Given this list of marker genes HOXA7, HCAR3, SSX9P, GLB1L3, LOX, GPR27, SCN3A, BAZ1A, DLGAP4, KRTAP15-1, RTL3, CEP15, KCTD5, IGF1, SLITRK4, NDRG2, GPM6A (NCBI Gene Id 2823), TPT1P8 (TPT1 pseudogene 8), FIGN, EYA1, ADNP2, HNF1B, P2RY10, MBD5, PDE4D, PLAG1, DLG2, SSX7, HOXD4, LDB2, MBNL1, SRSF1, PPP1R36, CHD9, PDZRN4, VPS37A, UCMA, MNT, SULF2, ID4, TRERF1, DHRS4, LIN54 (lin-54 DREAM MuvB core complex component), HOXB8, GNAO1, GPC4 (NCBI Gene Id 2239), DPYSL3, CDC42EP3, KLHL13, LMO3, DCANP1, ANK3, PHOX2B, MID2, NFIA, MPPED2, GPRIN3, PITX2 (NCBI Gene Id 5308), MECOM, MCTS1, DLX1, DUSP10, CCDC116, CIAO1, KLF15, CELF2, OMG, H2AC1, MAF, SRSF6, BRINP3, TLE3, DCUN1D3, SEMA6A (semaphorin 6A), ELP4, FEZF2, HNRNPLL, NDST4, MAP4K5, FGF19, SATB1, GRM7, KLHL11, TSNAX, INPP4A, EP300 (E1A binding protein p300), BCL2, ZRANB1, ERBB4, CETN1, YRDC, C1orf122, IMMP1L, NCOA3, TENM3-AS1, NFIB, H3-3B, OPN5, TMEM178A (transmembrane protein 178A), SERTAD4, PLXNA2, SLC26A7, HIPK1 (NCBI Gene Id 23323), AMMECR1, ZEB1, PCDHGA1, PIPOX, NRAS, LRMDA, ZBTB20, SRPK2, HOXC11, AICDA, CREB5, OLIG3, ODF1, FOXN3, SSX5, TTBK2, NSD1, RPA2, CLN5, LMO1, PELP1, OSBPL6, FOXP1, BEND4, ALDH1A2, FDX2, CNTF, ZNF296, ANXA8, PART1, FSBP, SLC44A1, ZBTB10, STC1, SOX5, ATP5MC2, NPR3, TAFA1, FGF12, KRTAP8-1, USP28, CNMD, CPNE1, TCEAL1, PACSIN3, LGI1, FGFR3, VPREB3, PIM2, RARB, GALNT12 (NCBI Gene Id 79695), VAMP2, NLK (NCBI Gene Id 51701), MTRF1L, REST, HCAR2, ELOA2, NOL4, SCAF4, PROKR2, GEMIN7, CNFN, TMEM127, PALMD, CBFA2T2 (NCBI Gene Id 9139), EIF4E, SOST, FOXP2, CHML, GARRE1, ASCL3, PTPN1, RBFOX1, CARS1, CHD2, HNRNPA0, FBXW7, SH3BGRL, NTRK3, NFYB, ENSG00000291228, SCNN1A, ATP13A3, CDKL5, TKTL2, DCLK1, YTHDC2, IRX3, KCNQ1DN, H2BC1, SEMA6C, ZFPM1, AMIGO3, PRRX1, AGRP, SYNE2, MSR1, CUX1, CREBZF, PEPD, LRRN1, LRRTM3, NR2F1, ELAVL2, KRTAP11-1, LUC7L3, SCUBE3, STMN2, EIF4A1, SOX18 (SRY-box transcription factor 18), HTR4, HABP2, CCN1, SREK1, EN1, NME3, HOXC4, PAX2, HOXD11, RUSC1-AS1, ARF3, HOXD8, PMP22, CTSK, ZHX2, E2F3, KBTBD8 (kelch repeat and BTB domain containing 8), SAT1, LINC01164, PKP4, NEUROD6 (neuronal differentiation 6), NPTX2, HNF4G, SSX3, ASAH1, WNT6, PLSCR2, THAP12, OTX1, RALYL, WDR33, ATP2B1, SLC4A4, CD36, NEUROG1, CACNA1D, GABRQ, AGBL2, ZNF366, LY6G5B, HOXB4, POLG2, TP53INP2, CELF4, BDNF (NCBI Gene Id 627), RCOR1, FSIP2, HOXA11, HS3ST1, MARCKSL1, LYRM1, ATP1B1, IRX2, CACNB3, EVA1C, here is a description of the gene set: Genes having at least one occurrence of the motif CWNAWTKWSATRYN in the regions spanning 4 kb centered on their transcription starting sites. This matches the POU2F1 transcription factor binding site V$OCT1_06 (v7.4 TRANSFAC). studied in species Homo sapiens Human Gene Set: OCT1_06